Given this list of marker genes Gon4l, Gigyf2, Sft2d3, Stab1, B3galnt2, Washc3, Snhg12, E330037G11Rik, Ildr2, here is a description of the gene set: Mouse Gene Set: TERAMOTO_OPN_TARGETS_CLUSTER_5 Cluster 5: genes whose up-regulation peaked 5 days after knockdown of OPN by RNAi in the NIH3T3 cells (fibroblasts) transformed by activated HRAS. from publication Teramoto H, Castellone MD, Malek RL, Letwin N, Frank B, Gutkind JS, Lee NH (PMID 15516973) Activated forms of Ras family members are prevalent in many cancers where Ras mutants transduce signals essential for transformation, angiogenesis, invasion and metastasis. As a cancer progression model, we used NIH3T3 cells to explore the mechanism of Ras-induced tumorigenesis. Ras family mutants H-RasV12 and Rit79L strongly induced foci formation, while Rho family mutants RhoA-QL, Rac1-QL and Cdc42-QL were less effective. A comparison of downstream transcriptional targets of Ras and Rho family members using a 26 383 element cDNA microarray revealed that the osteopontin (OPN) gene exhibited the best correlation between magnitude of gene expression change and level of foci formation (r=0.96, P<0.001). In association with H-RasV12- and Rit79L-mediated transformation, foci secreted OPN protein and upregulated the OPN receptor CD44, suggesting the novel initiation of an aberrant OPN-CD44-Rac autocrine pathway. In support of this were the following observations. First, RGD-deficient OPN protein-binding activity was present in H-RasV12-transformed cells but not in control cells, and binding activity was inhibited by the CD44 blocking antibody. Second, foci formation, cell invasion and Rac activity were induced by H-RasV12 and inhibited by the CD44 blocking antibody. Third, foci formation by H-RasV12 was substantially reduced by a short interfering RNA (siRNA) specifically targeting OPN expression for knockdown. Fourth, H-RasV12-mediated transformation was not blocked by the GRGDS peptide, suggesting that OPN effects were not mediated by the integrins. Lastly, OPN knockdown affected the downstream expression of 160 '2nd tier' genes, and at least a subset of these genes appears to be involved in transformation. Indeed, four genes were selected for knockdown, each resulting in a disruption of foci formation and/or invasion. These results underscore the role of aberrant autocrine signaling and transcriptional networking during tumorigenesis. species: Mus musculus